The following is a description of a gene set: Human Gene Set: KEGG_MEDICUS_VARIANT_MUTATION_INACTIVATED_ATP1A1_TO_ANGIOTENSIN_ALDOSTERONE_SIGNALING_PATHWAY species: Homo sapiens Pathway Definition from KEGG: ATP1A1* -> Na+ -> (CACNA1D,CACNA1H) -> Ca2+ -> CALM -> CAMK -> CREB => CYP11B2 -> Aldosterone Mutation-inactivated ATP1A1 to angiotensin-aldosterone signaling pathway. Pathway ID: N00304. Pathway type: Variant. Pathway class: nt06316 Renin-angiotensin-aldosterone signaling., and this is the list of marker genes: ATP1A1, CREB3L1, CAMK4, CREB3L4, CAMK1D, CYP11B2, CALM3, CREB5, CALM1 (calmodulin 1), CREB3L2 (NCBI Gene Id 64764), CAMK1, ATF4, ATF2, CAMK2D, CREB3L3, CACNA1H, CAMK2A, CAMK2B, CACNA1D, CAMK2G, CAMK1G, CREB3, CALM2, CREB1, ATF6B